The following is a description of a gene set: studied in species Homo sapiens Any process that modulates the frequency, rate or extent of a signaling receptor activity. Receptor activity is when a molecule combines with an extracellular or intracellular messenger to initiate a change in cell activity. Human Gene Set: GOBP_REGULATION_OF_SIGNALING_RECEPTOR_ACTIVITY, and this is the list of marker genes: SLURP2, PATE4, CNRIP1, CAV3, RAMP3, ADAM17, CRHBP, CLEC12B, CACNG7 (NCBI Gene Id 59284), GREM2, FSHB, VPS25, CRH, OPRM1, PRRT1, CACNG8, MINK1, NCOA3, CACNG2, PSCA, ZFYVE28, TSG101, ZGPAT, CNIH3, TAFA1 (NCBI Gene Id 494552), CACNG5, IL24, CACNG3, DAPK1, CNIH2, SOCS5, SNX6, IL20, GPRC5A, LYNX1, IL19, IL26, CGA, ERRFI1, IL10, SHISA7, CACNG4, SOCS4, CHMP6, TAFA4